The following is a description of a gene set: studied in species Homo sapiens Human Gene Set: chr1q22, and this is the list of marker genes: GLMP, SYT11, SSR2, PMF1, HCN3 (NCBI Gene Id 57657), MEF2D, FDPS, IQGAP3, ENSG00000285677, RAB25, LAMTOR2, VHLL, MEX3A, RUSC1, SCAMP3, SEMA4A, DAP3P1, ARHGEF2-AS1, MSTO2P, RHBG, GON4L, SLC25A44, ARHGEF2-AS2, GBA1LP, TTC24, RIT1, THBS3-AS1, RXFP4, THBS3, UBQLN4, DAP3, CLK2, ASH1L-IT1, ENTREP3, NAXE, TRIM46, KHDC4 (NCBI Gene Id 22889), PKLR, MIR9-1HG, PAQR6, SNORA80E, TMEM79, SCARNA4, MUC1, MTX1LP, SMG5, EFNA1, MIR9-1, MIR555, HMGN2P18, DPM3, MTX1, RNU6-106P, BGLAP, MIR6738, RNU6-1297P, GBA1, POU5F1P4, RUSC1-AS1, PMF1-BGLAP, CCT3, ASH1L-AS1, MSTO1, SLC50A1, YY1AP1, MIR92B, KRTCAP2, LMNA, ASH1L, ARHGEF2, TSACC